The following is a description of a gene set: studied in species Homo sapiens Human Gene Set: ATAGGAA_MIR202 Genes having at least one occurence of the motif ATAGGAA in their 3' untranslated region. The motif represents putative target (that is, seed match) of human mature miRNA hsa-miR-202* (v7.1 miRBase)., and this is the list of marker genes: ATXN1, ESR1, EAF1, RAD52, PRMT8, GID8, VANGL2, DDX3X, ANP32E, LUZP1, NDRG1, TARDBP, CPEB3, CBL, ACTN1, ENAH, BICD2, DNAJC10, MED13L, TTC13, USP8, SINHCAF, FAM76B, GPBP1L1, ZNF362, LEMD3, PGAP1, EI24, TENT5C, RASA1, ESRP2, CD28, NAA15, BAG4, ERBIN, HOXB2, CREBBP, SENP1, ELF1, STOX2, ANKRD13A, SUCO, APPBP2, ASAP1, ARSB, LNPK, ZNF652, KRAS, PPP5C, KIAA0408, NR2F2, RNF11, TYW5, LBR, MEX3B, ATP2B4, RAB22A, BCL2, SNX16, RPS6KA3, PLEKHA1, CTBP2, KLF12, USP15, MARCKS, HLF, KMT2A, LHFPL3, SSBP2, ACSL3, CNOT6 (CCR4-NOT transcription complex subunit 6), PTEN, IQGAP1, RNF121, EIF4E3, SORCS1, CCDC88A, SCN2B, MSL2, ACVR1, LDLRAD3, TRIM33, BTG1, TGFBR2, MAPK6, TCF12, GRIA3, PCGF2 (NCBI Gene Id 7703), UBE2K, ROBO2, SMG7, YAF2, BCL11A, SPRED1, SFPQ, STAT3, CNN3, KHDRBS2, MIB1, SNAP91, MED1, ZFAND3